The following is a description of a gene set: studied in species Homo sapiens from publication Browne EP, Wing B, Coleman D, Shenk T (PMID 11711622) Genes down-regulated in primary fibroblast cell culture after infection with HCMV (AD169 strain) at 24 h time point that were not down-regulated at the previous time point, 20 h. Human Gene Set: BROWNE_HCMV_INFECTION_24HR_DN The effect of human cytomegalovirus (HCMV) infection on cellular mRNA accumulation was analyzed by gene chip technology. During a 48-h time course after infection of human diploid fibroblasts, 1,425 cellular mRNAs were found to be up-regulated or down-regulated by threefold or greater in at least two consecutive time points. Several classes of genes were prominently affected, including interferon response genes, cell cycle regulators, apoptosis regulators, inflammatory pathway genes, and immune regulators. The number of mRNAs that were up-regulated or down-regulated were roughly equal over the complete time course. However, for the first 8 h after infection, the number of up-regulated mRNAs was significantly less than the number of down-regulated mRNAs. By analyzing the mRNA expression profile of cells infected in the presence of cycloheximide, it was found that a minimum of 25 mRNAs were modulated by HCMV in the absence of protein synthesis. These included mRNAs encoded by a small number of interferon-responsive genes, as well as beta interferon itself. Cellular mRNA levels in cytomegalovirus-infected cells were compared to the levels in cells infected with UV-inactivated virus. The inactivated virus caused the up-regulation of a much greater number of mRNAs, many of which encoded proteins with antiviral roles, such as interferon-responsive genes and proinflammatory cytokines. These data argue that one or more newly synthesized viral gene products block the induction of antiviral pathways that are triggered by HCMV binding and entry., and this is the list of marker genes: ABCC1, FGF8, AP4S1, B2M, SSPN, MGMT, CDON, CRIM1, COL13A1, FBN1, DRD3, GRIA3, KCNMA1, TMEM187, ALDH1A1, GRIK2, KIAA0930, MGST3, RECK, LAMA4, FIG4, ABCA8, RIPOR2, DDAH1, EXT1, IGFBP3, RHOA, TPM2, BNIP3L, IGFBP5, YLPM1, COL5A2, PRKAB2, HIPK2, PRSS23, RAB4A, FGF1, PRKG1, TKT, CALD1, MEST, COL8A1, TP53I3, SSH1, CDH13, RDH5, SUCLG2, MXRA5, THBS1 (thrombospondin 1), LPAR1, RPS6KA2, BTG1, RRAS2, ITGA2, CROCC, DBP, COL6A3, PDLIM7, B9D1, MMP1, SPAG5, HOXA11, TAF1B, FBN2, CD44, UROS, CEMIP (NCBI Gene Id 57214), PTPN13, TM7SF2, CCN3, DIAPH2, PAMR1, DDX17, CA12, SLC14A1, S100A10, ANXA4, PTPRM, NIPAL3, CFLAR, AP3S2, S100A4, ACOX1, CAV1, ERVK-28, ACTA2, ECI1, TGFBR2, LGALS3 (galectin 3), BLK, BST1, SEPTIN11, DST, FDPS, SEMA3C, PTEN, KIT, OLFML1, PRIM2, PKLR, IFITM1, RIN2, HOXA9, GPR176, ERCC2, GJA4, ANGPT1, CPS1, ATP5PD, LAMC1, ARHGEF9, DNMBP, CD59, MYH8, CCNG1, CDKN1A, CTSO, TEAD1, SGCB, BACH1, GDF10, GAS6, SEMA5A, BIRC5, GSTT1, PDE1C, PDGFRB, SLC16A4, FADS1, CXCR2, BTN3A3, POLR3G, PARVA, TIMP3, VWA5A, OAZ1, SLC16A2 (solute carrier family 16 member 2), MXD4, MTMR11, NR1H3, N4BP3, UBB, PRKCA (protein kinase C alpha), TRAPPC12, ACSM3